The following is a description of a gene set: Mouse Gene Set: GOCC_TORC2_COMPLEX A protein complex that contains at least TOR (target of rapamycin) and Rictor (rapamycin-insensitive companion of TOR), or orthologs of, in complex with other signaling components. Mediates the phosphorylation and activation of PKB (also called AKT). In Saccharomyces, the complex contains Avo1p, Avo2p, Tsc11p, Lst8p, Bit61p, Slm1p, Slm2p, and Tor2p. studied in species Mus musculus, and this is the list of marker genes: Rictor, Mtor, Prr5, Mlst8, Sesn3, Mapkap1, Tti1, Prr5l (NCBI Gene Id 74608), Sesn2